Given this list of marker genes UGDH, EP300, BRCA1, GJA5 (NCBI Gene Id 2702), TBX15, ZBTB18, LARP7, CDK13, PALB2, UBE2T, USP9X, DCHS1, AFF3 (ALF transcription elongation factor 3), LIFR, RFWD3, KCNJ2, SOX6, FANCI (NCBI Gene Id 751608), RBPJ, CHD4, HUWE1 (NCBI Gene Id 54789), DONSON, FANCG, SNX14, KCNJ5, PUF60, TAF4, RAD51, POLA1, SOX11 (SRY-box transcription factor 11), MOGS, SMC5, FANCA, HNRNPR (NCBI Gene Id 10236), ERMARD, RBM10, FBXL4, PAX3, XRCC2, SLC2A10, RTL1, ALDH1A3, SMAD4, H4C5, UBE3B, KANSL1, PPP1R12A, ALX4, AUTS2, MADD, BRIP1, RAP1B, ERCC4, STT3A, SETBP1, DLK1, TMEM107, DDX3X, RAD51C, DRG1, BCL11B, FANCE, BBS2 (NCBI Gene Id 583), CHN1, BRCA2, PIEZO2, SLC25A24, FANCB, WAC, GJA1, PRMT7, SMARCA2, MAPRE2, KMT2A, FANCM, KIF15, SLX4, BPTF (bromodomain PHD finger transcription factor), MEG3, DDB1, MYCN, POLR1A, TBX1, MAD2L2 (mitotic arrest deficient 2 like 2), PRKAR1B, FANCD2, THOC6, MUSK, B3GLCT, EXOSC2, SETD2, SOX9, SMPD4 (NCBI Gene Id 94852), KAT6B, FOXP2, CLTCL1, MAFB, GJA8, STAC3, ADNP, FAT4, ORC1, NUAK2, HNRNPH2, LMNA, CREBBP, SMOC1, ZMPSTE24, TUBB, FANCF, FANCL, SIN3A, KRAS, TXNL4A, FBXO28 (NCBI Gene Id 23219), PIGA, SEPTIN9, COG7, ZNF148, MAGEL2, CEP57, SALL4, FANCC, here is a description of the gene set: Human Gene Set: HP_SHORT_PALPEBRAL_FISSURE Distance between the medial and lateral canthi is more than 2 SD below the mean for age (objective); or, apparently reduced length of the palpebral fissures. studied in species Homo sapiens Short palpebral fissure